The following is a description of a gene set: The chemical reactions and pathways resulting in the formation of ceramides, any N-acylated sphingoid. Mouse Gene Set: GOBP_CERAMIDE_BIOSYNTHETIC_PROCESS species: Mus musculus, and this is the list of marker genes: Ormdl3, Ormdl1, St3gal2, B3galt4, Ccn1, Degs2, St6galnac5, Gsdmd (NCBI Gene Id 69146), P2rx1, Sgms1, Pla2g6, B3galt2, Gal3st1, Gm6993, Smpd2, Smpd3, Agk, Sphk2, B4galt5, B4galt4, Sptssb, Enpp7, Cers6, Sptlc1, Cers5, Cers3, Degs1l, Cers4, Samd8, Mecr, Sphk1, B4galt6, Smpd5, Prf1, Cers1, Sptlc3, Ugt8a, Ormdl2, B4galnt1, Cyp4f39, Asah2, Gzmb, Gba1, Prkcd (protein kinase C, delta), Aloxe3, Pnpla1, Asah1, Sptlc2, Cers2, St8sia4, Tlcd3b, St8sia3, Sgms2, Degs1, St8sia2, B3galt1, St6galnac4, St6galnac6, Casp1, Alox12b, P2rx7, St3gal1, 6430550D23Rik, Elovl1, Sirt3, Sptssa, Paqr4, Smpd4, St6galnac1, Smpd1, Casp7, St3gal3, Zfp750, B4galt3, Ugcg, St6galnac3, Fa2h, St8sia6